Given this list of marker genes Stx1b, Syt1, Rims1, Ppp1r9a, Doc2g, Doc2a, Rims2, Unc13b, Rph3a, Prkn, Doc2b, here is a description of the gene set: Neurotransmitter secretion that occurs in the absence of the action of a secretagogue or a presynaptic action potential. Mouse Gene Set: GOBP_SPONTANEOUS_NEUROTRANSMITTER_SECRETION species: Mus musculus